The following is a description of a gene set: Any process that stops, prevents, or reduces the frequency, rate or extent of cardiac muscle growth. species: Homo sapiens Human Gene Set: GOBP_NEGATIVE_REGULATION_OF_CARDIAC_MUSCLE_TISSUE_GROWTH, and this is the list of marker genes: MIR200B, MIR17HG, PI16, NOG (NCBI Gene Id 9241), TBX5, RBP4, MAPK11, MIR199B, TOMM70, MIR1-1, PAK1, YY1, G6PD, MIR873, TP73, CAV3, SAV1, CTDP1, MIR199A1, RGS4, GSK3A, JARID2, RGS2, VGLL4, FOXP1, PPARA, MIR25, KCNK2